The following is a description of a gene set: from publication He P, Lim K, Sun D, Pett JP, Jeng Q, Polanski K, Dong Z, Bolt L, Richardson L, Mamanova L, Dabrowska M, Wilbrey-Clark A, Madissoon E, Tuong ZK, Dann E, Suo C, Goh I, Yoshida M, Nikolić MZ, Janes SM, He X, Barker RA, Teichmann SA, Marioni JC, Meyer KB, Rawlins EL (PMID 36493756) Human Gene Set: HE_LIM_SUN_FETAL_LUNG_C0_MYOFIBROBLAST_2_CELL species: Homo sapiens Myofibro 2, and this is the list of marker genes: FAM118A, PLEKHG1, CT45A5, SLC4A4, COL27A1, KCNK5, LRP4, CT45A3, C1QTNF7, REEP1, PCSK7, DACH2, MPP1, MYH11, SEMA3C, CT45A8, PCSK1N, ARHGAP6, ISM1, COL12A1, LEF1, ANO1, ACTG2, SLC9A6 (solute carrier family 9 member A6), TMEM100, TSPAN2, TBX5-AS1, VSNL1, ZEB1, PRAG1, PLPPR4 (NCBI Gene Id 9890), PLXNA2, JCAD, ITPRIPL2, MT1X, WIF1, IL21R, MCTP2, ATP6V0E2 (ATPase H+ transporting V0 subunit e2), NKD1, NEDD9, HTRA1 (NCBI Gene Id 5654), MTARC1, FENDRR, STK17A, SLC26A2, RUNX1, SYT1, SORT1, MMGT1, EYA4, LTBP2, PCSK5, IGSF1, C1QTNF5, ADAMTSL2, COL24A1, CT45A2, ITPK1, SYNDIG1, STC1, EOGT, CT45A7, NOTUM, FGF18, SERPINE1, PTGER2, PAG1, RGN, CXCL14, TYRP1, ALKAL1, CT45A1, ITGA9, SCG5, ETV5, SSC5D, THBD, RAI2, SNED1, TPST2, FBXL22, ENC1, LRRTM1, ANO4, WNT11, CPZ, WNT5A, MT1E, CT45A9, CTXND1, ABR, CT45A10, RGCC, KCNK17, SMIM3, SLCO2A1, MYOCD, PLXNA4, IGF1, C16orf89, CT45A6, NRCAM (NCBI Gene Id 4897), ZNF536